The following is a description of a gene set: Reactome Pathway: TRAF6-mediated induction of TAK1 complex within TLR4 complex part of: TRIF (TICAM1)-mediated TLR4 signaling  In human, together with ubiquitin-conjugating E2-type enzymes UBC13 and UEV1A (also known as UBE2V1), TRAF6 catalyses Lys63-linked ubiquitination. It is believed that auto polyubiquitination and oligomerization of TRAF6 is followed by binding the ubiquitin receptors of TAB2 or TAB3 (TAK1 binding protein 2 and 3), which stimulates phosphorylation and activation of TGF beta-activated kinase 1(TAK1).<p>TAK1 phosphorylates IKK alpha and IKK beta, which in turn phosphorylate NF-kB inhibitors - IkB and eventually results in IkB degradation and NF-kB translocation to the nucleus. Also TAK1 mediates JNK and p38 MAP kinases activation by phosphorylating MKK4/7 and MKK3/6 respectivly resulting in the activation of many transcription factors. <p>The role of TRAF6 is somewhat controversial and probably cell type specific. TRAF6 autoubiquitination was found to be dispensable for TRAF6 function to activate TAK1 pathway. These findings are consistent with the new mechanism of TRAF6-mediated NF-kB activation that was suggested by Xia et al. (2009). TRAF6 generates unanchored Lys63-linked polyubiquitin chains that bind to the regulatory subunits of TAK1 (TAB2 or TAB3) and IKK(NEMO), leading to the activation of the kinases.<p> Xia et al. (2009) demonstrated in vitro that unlike polyubiquitin chains covalently attached to TRAF6 or IRAK, TAB2 and NEMO-associated ubiquitin chains were found to be unanchored and susceptible to N-terminal ubiquitin cleavage. Only K63-linked polyubiquitin chains, but not monomeric ubiquitin, activated TAK1 in a dose-dependent manner. Optimal activation of the IKK complex was achieved using ubiquitin polymers containing both K48 and K63 linkages.<p>Furthermore, the authors proposed that the TAK1 complexes might be brougt in close proximity by binding several TAB2/3 to a single polyubiquitin chain to facilitate TAK1 kinase trans-phosphorylation. Alternativly, the possibility that polyUb binding promotes allosteric activation of TAK1 complex should be considered. studied in species Homo sapiens, and this is the list of marker genes: MAP3K7, LY96, TICAM1, TICAM2, UBC, TRAF6, UBB (NCBI Gene Id 91253), TLR4, UBA52, IRAK2, TAB2, CD14, TAB3, RPS27A, SARM1, TAB1